The following is a description of a gene set: Human Gene Set: GOBP_NEGATIVE_REGULATION_OF_DIGESTIVE_SYSTEM_PROCESS species: Homo sapiens Any process that decreases the frequency, rate or extent of a digestive system process, a physical, chemical, or biochemical process carried out by living organisms to break down ingested nutrients into components that may be easily absorbed and directed into metabolism., and this is the list of marker genes: TIFAB, NEUROG1, STK39, WNK4, SCT, ABCG8, TFF2, NPSR1, NMU, DCANP1 (NCBI Gene Id 140947), HAMP, NR1H3, WNK3, PTGER3, WNK1, ABCG5